The following is a description of a gene set: from publication Howard LM, Hoek KL, Goll JB, Samir P, Galassie A, Allos TM, Niu X, Gordy LE, Creech CB, Prasad N, Jensen TL, Hill H, Levy SE, Joyce S, Link AJ, Edwards KM (PMID 28099485) species: Homo sapiens Human Gene Set: HOWARD_NEUTROPHIL_INACT_MONOV_INFLUENZA_A_INDONESIA_05_2005_H5N1_AGE_18_49YO_1DY_UP BACKGROUND: Vaccine development for influenza A/H5N1 is an important public health priority, but H5N1 vaccines are less immunogenic than seasonal influenza vaccines. Adjuvant System 03 (AS03) markedly enhances immune responses to H5N1 vaccine antigens, but the underlying molecular mechanisms are incompletely understood. OBJECTIVE: We compared the safety (primary endpoint), immunogenicity (secondary), gene expression (tertiary) and cytokine responses (exploratory) between AS03-adjuvanted and unadjuvanted inactivated split-virus H5N1 influenza vaccines. In a double-blinded clinical trial, we randomized twenty adults aged 18-49 to receive two doses of either AS03-adjuvanted (n = 10) or unadjuvanted (n = 10) H5N1 vaccine 28 days apart. We used a systems biology approach to characterize and correlate changes in serum cytokines, antibody titers, and gene expression levels in six immune cell types at 1, 3, 7, and 28 days after the first vaccination. RESULTS: Both vaccines were well-tolerated. Nine of 10 subjects in the adjuvanted group and 0/10 in the unadjuvanted group exhibited seroprotection (hemagglutination inhibition antibody titer > 1:40) at day 56. Within 24 hours of AS03-adjuvanted vaccination, increased serum levels of IL-6 and IP-10 were noted. Interferon signaling and antigen processing and presentation-related gene responses were induced in dendritic cells, monocytes, and neutrophils. Upregulation of MHC class II antigen presentation-related genes was seen in neutrophils. Three days after AS03-adjuvanted vaccine, upregulation of genes involved in cell cycle and division was detected in NK cells and correlated with serum levels of IP-10. Early upregulation of interferon signaling-related genes was also found to predict seroprotection 56 days after first vaccination. CONCLUSIONS: Using this cell-based systems approach, novel mechanisms of action for AS03-adjuvanted pandemic influenza vaccination were observed. TRIAL: ClinicalTrials.gov NCT01573312. Genes up-regulated in neutrophil 1d vs 0d in adults (18-49) after exposure to inactivated monovalent influenza A/Indonesia/05/2005 H5N1 split-virus vaccine, time point 1D, administered i.m., and this is the list of marker genes: HLA-DMA, RHOC, VPS13C, GYPC, RNF43, APOBEC3D, HLA-DRB5, ARMH1, ERI1, MICB, CASP5, DNAJC1, SERPINB9, WHRN, CISH, IDO1, NAA15, RSAD2 (NCBI Gene Id 91543), NCOA7, SLC25A28, ATR, TRIM69, TMEM268, TMEM62, ARL2, BTN3A3, ZNF496, TMEM229B, TFEC (NCBI Gene Id 22797), PIK3AP1, CARD16, EPB41L5, GLS, BPI, WDFY1, RBCK1 (NCBI Gene Id 10616, RANBP2-type and C3HC4-type zinc finger containing 1), KPTN, PSMB9, IL18R1, IRAK2, TMEM272, MR1, RIPK2, GVINP1, BST2, PCGF5, IGF2BP3, CACNA1E, NOD2, FCRL2, IFIT3, NLRC5, BTLA, TIMM10, PAN2, RAB20 (NCBI Gene Id 55647), MED12L, IFIT5, GIMAP2, SAMD9L, SP140, AGPAT3, VAT1, GIMAP1, CD274, RASGRP3, CTRL, LY6E (lymphocyte antigen 6 family member E), SLC25A22, KDSR, FCGR1BP, IFI6, ISG20, PPP2R5B, EZH2, DTX3L, PARP11, STN1, SORT1, SOCS1, SIAH2, LMTK2, TBC1D8, IFI30, LAMP3, DDX60, CFAP410, GSDMD, CEACAM1, RFX5, CNTRL, CD7, ECHS1, HERC5, SPATS2L, TARS1, GSTK1, MDK, TYMP, KIF24, TRIM21, CD69, PSMB10, CD74, CMC2, SMTNL1, BATF, IFT56, CNIH4, ERAP2 (NCBI Gene Id 87126), IGFLR1, LIMK1, NPC2, KIAA0930, PSME2P2, KLF5, TRIM5, GBP6, WARS1, CNDP2, PARP10, RANGAP1, APOL1, KCNJ15, LAP3, PI4K2B, STK3, PUS3, NRADDP, IFI44L, EIF4G3, MSRB2, CAPNS2, SAMHD1, DTNBP1, GAS8, CMTR1, BAK1 (BCL2 antagonist/killer 1), APOL3, NOL10, WDR86, PSME2, PARP12, GCH1, RNASEH2B, DNPEP, PPM1K, FAM241A, DDX60L, ANKRD22, CREG1, SLFN5, HERC6, RIGI, NUB1, FRMD4B, CALHM6, DOCK4, RHBDF2, ETV7, EMC9, ANXA3, IKZF4, BAK1P1, AANAT, CIMAP1B, ACO1, RPS2P5, ERLIN1, HLA-DRB1, PPP1R2P1, CASP7, NAPA, PCED1B (NCBI Gene Id 91523), BATF2 (basic leucine zipper ATF-like transcription factor 2, NCBI Gene Id 116071), STAMBPL1, SSB, BPNT1, C3AR1 (NCBI Gene Id 719, complement C3a receptor 1), GADD45B, EPSTI1, CARD17P, DDIAS, GRINA (glutamate ionotropic receptor NMDA type subunit associated protein 1), ICAM1, GALM, H2BC18, LIPA, ID3, RSPH9, SCARF1, ISG15, BLOC1S6, LPCAT2, POLB (DNA polymerase beta), HLA-K, IFI35, AIM2, SCRN1, GBP4, FZD5, SH3PXD2A, CMPK2, VPS9D1, FANCA, CPNE5, FAM111A, ATP1B3, DHX58, CETP, SELENOI, APOBEC3G, IRF9, IFITM3, TRIM38, AP1AR, XRN1, HLA-DOB, SRBD1, MVB12A, ZBP1, CD2AP, BRCA2, SNX20, IFIT1, PSTPIP2, CGAS, PDCD1LG2, CIITA, RILP, STX11, EXOC3L1, VRK2, GBP1P1, TMSB10, CMAHP, STOM, ITPRIPL2, MOV10, DEXI, PARP14, GBP3, AFF1, OAS2, STAT1, ATP10D, NRN1, SLAMF7, TLR5 (NCBI Gene Id 95519), UBE2L6, IFIT2, TNFSF13B, KARS1, APOL6, DUSP5, FANCL, GRIP1, APOL2, VAMP5, PCK2, PARP9, EIF2AK2, ACSL5, GBP1, TNFAIP6, SEPTIN4, OAS3, C19orf12, DDX51 (NCBI Gene Id 317781), LHFPL2 (LHFPL tetraspan subfamily member 2), FLT3LG, HLA-DRA, RMI2, RCVRN, IL12RB1, FCGR1A, MRPL44, DDX21, APOBEC3C, ARHGAP5, GPR65, CREB3L2, MAFF (NCBI Gene Id 23764), SLC26A8 (NCBI Gene Id 65016), MT2A, HLA-DMB, CD59, PML, IFIH1, IFI44, IRF1, STAT2, GADD45G, IFI16, FBXO6, NOD1, C5, OAS1, ASPHD2, N4BP2L1, GSTO1, FCER2, FAM135A, IL15RA, PRR5L, SEPHS2, NDUFA9, SESTD1, SERPINB6, GBP2, GBP5, CLEC5A, UBR1, TTC39B, LACTB (NCBI Gene Id 84943), C4BPA, RHOH, APOL4, NASP, MTHFD2, TLDC2, TSPAN17, FERRY3, ENTPD6, PRRG4, HELB, SPHK1, MX1, EFCAB2, DENND1A, SLC43A3, CACNA1A, LOXL1, HEBP1, TAP1, OASL, APOBEC3F, NT5C3A, P2RY14, MATCAP1, USP30, GRAMD1B, EPG5, IFITM1, RBM43, CTSA, SERPING1, LIPM, ZC3H7B, ZCCHC2, HLA-DQB1, PDE4B, TARBP1, FRMD3, STX17, NUP205 (NCBI Gene Id 23165), USP42, SMCO4, KLF4, XAF1, CD22, PLSCR1, PLAAT4, SPTSSA, TIFA, CCRL2, PSME1, KLHDC7B, ZC3HAV1, ATF3, C22orf23, SLK, TRAFD1, REC8, TRIM22, TRIM6, ANO6, PLSCR2, MITD1, STOML1, RTP4, PSMB8, SECTM1, TAP2, KREMEN1, CARINH, NUCB1, RNF144A (ring finger protein 144A), SCO2 (NCBI Gene Id 9997), IRF7, ANXA2R, MICALL1, CASZ1, RNF213